The following is a description of a gene set: Human Gene Set: GOBP_RESPONSE_TO_THYROGLOBULIN_TRIIODOTHYRONINE studied in species Homo sapiens Any process that results in a change in state or activity of a cell or an organism (in terms of movement, secretion, enzyme production, gene expression, etc.) as a result of a Thyroglobulin triiodothyronine stimulus., and this is the list of marker genes: NCOA2, NCOA1, SLC2A1, INHBB, GLB1